Given this list of marker genes THSD1, ACOX2, SPEF1 (NCBI Gene Id 25876), GNAZ, BMERB1 (NCBI Gene Id 89927), AFP, VPS13C, UMOD, FGFBP2, CDH2 (NCBI Gene Id 1000), H3C11 (NCBI Gene Id 8354), ZNF765, XCL2, KLHL28, TTLL4, EFNB3, MAPK8IP2, ARHGAP24, RAD54B, MAGOHB, GAS5, SIGLEC9, TAF4, TMEM158, CPN2, DGKI, APOH, FGF7, SLC30A9, KLHL25, NUP160, IL18BP, SEMA3C, LOXL1, PTGIS, EXOC7, ZKSCAN3, GATA6, PDE1A, SLC36A1, PAX2, PRKD1, CFHR1, PITPNB, PCDH17, BPI, TOR1B, CHEK1, TLR3, BACE2, FBN3, SPINK1, KIFC1, ABCC13, AURKC (NCBI Gene Id 6795), MAP6, DDT, FMOD, NUDT4, CRYGC, TNFRSF11B, PTBP2, COMP, ESRP2, NREP, TMEM190, MUC4, RIC1, PHF14, COX4I1, INA, RAB29, IL1RAP, F12, TTTY11, BMAL1, R3HDM4, ADRA2A, CRMP1, MYNN, SLC22A2, ZFP28, LGR4, PPP2R3A, CACNA2D1, ITGA9, GRB14, TMEM14A, here is a description of the gene set: Genes in the cancer module 544. Human Gene Set: MODULE_544 species: Homo sapiens